Given this list of marker genes Nt5m, Sar1b, Psmg3, Cfap418, Hebp2, Gm12059, Cdiptos, Rrp1b, Timm10, Akain1, Mef2a, Chrna1os, Rptor, Zfp704 (NCBI Gene Id 269407), Nectin3, Vps18, 1810024B03Rik, Ddx1, Kics2, Disp3, Oma1, Rap1a, Brf2, Gm24016, Tm2d1, Ccnc, Taco1, Myc, Rps27l, Ttk, Tmem101, Gm21092, Mrps2, Polq, Vps51, Ptpn21, Usp28, Hs3st5, Ints1, Aloxe3, Rpph1, Dmap1, Jagn1, Rnf214, Exosc3, Ccdc107, Cacng2, Irak2 (interleukin-1 receptor-associated kinase 2), Mir7b, G0s2 (G0/G1 switch gene 2), Got2, Tmem147os, Wdr24 (NCBI Gene Id 268933), Gm20033, Snx18, Tor1aip2, Trim71, D030047H15Rik, Ly6g6e, Tars2, Spop, Hnrnpdl, Ubac2, Scarna2, Scp2, Tmbim4, Fbxl16, Mettl5, 4930558K02Rik, Blmh, Naf1, Kirrel1, Clptm1, Palb2, Zfp646, Pigc, Zfp637, Fbxo7, Bod1l, Med23, Xrn1, Niban2, Gfm2, Cnih4, Trub2, Pstk, Gpcpd1, Trpc4ap, Zfp738, Tatdn3, Tmem115, Ncam1, Dhrs13, Mei4, Zfp280d, Taf15, Rnu12, Abi2, Snord3a, Cul4a, Snord55, Ncbp3, Klhdc4, Eps15, Zfp90, Nipsnap1, Kmt2a, Anln, Scrib, Cntnap2, Epb41l4aos, Lama1, Mfap3l, Gm35986, Vgll3, Hnrnpd, Lamtor2, Gm6728, 4632404H12Rik, Dsg2, Max, Klhl35, Zfyve1, Tcea3, Ctbp1, Trp53bp2, Tmem270, Ndufa5, Rnf216, Tmem134, Calm1, Tmem106a, Gm10644, Fam149b, Gpc2, Magoh, Adrm1, Zfp609, Mrpl17, Scg3, Sp3os, Ap1ar, Rab33b, Hdac2, Ltbp2, Cpsf1, Zfp341, Tgif2, Frg2f1, Dusp28, Gm11292, Mup6, Taf4, Gm11175, Ppif, Plpp1, Ehd1, Prelid2, Ankrd40, Uchl5, Ints15, Plscr1, Syt7, Stx18, Lrrc75a, 5430400D12Rik, Nipsnap2, Cltc, Ephb4, Pcid2, Bcl3, Irf2bpl, Nkiras2, Denr (NCBI Gene Id 68184), Timm23, Sec63, 6430590A07Rik, Dcaf10, Gm5444, Slc33a1, Mien1, Mrps27, Zfp467, Gorasp2, Ndor1, Gm16046, Adam17, Plec, Matcap2, Man2c1os, Homer3, Mfsd4b5, Dab1, Kbtbd7, Cacnb3, Ccdc136, Akirin1, Galk2, Zfp69, Pdpk1, 8430429K09Rik, Rassf2, Pheta1, Psmd3, 1810041H14Rik, Gm13483, Exosc8, Dctn5, Bcat1, Rhot1, Mylpf, Fkbp1a, Cdca5, Rwdd1, Vps37d, Zfp790, Foxn3, Dhcr24, Kcnn2, Kcnb1, Gm11592, Polr1b, Zfpl1, Afg1l, Parm1, Sf3a3, Nanog, Gm16794, Ccdc88a (NCBI Gene Id 77927), Dpagt1, Gm26654, Mnat1, Gm12827, Snhg17, Reps1, Atxn1l, Mllt1, Tacc1, Topbp1, Ddit4, Gt(ROSA)26Sor, Tmem203, Ptcd2, Cops8, Cenps, Stoml2, Gm10433, Glis2, Cdkn2aip, Pafah1b3, Snord13, Tfam, Cnppd1, Ndrg3, Ube2ql1, Fcho2, Ube3c, Ctu2, Prkag1, Mphosph10, Cdk7, Eif3d, Gm26812, C920006O11Rik, Ptrh2, Litaf, Zdhhc17, Nop14, Gatad2b (NCBI Gene Id 404569), Gm26330, Patz1, Pxn, Efcab7, Cd63, Apba1, Rsrc2, Aars2, Zfp64 (NCBI Gene Id 22722), Pcnp, Apcdd1, Trmu, Parg, Eif3g, Pole3, Kbtbd4, Plekha4, Vmp1, Ypel1, Gucd1, Crot, Mrps31, Pik3c3, Sp3, Atad2b, Prrg2, Man2c1, Snora17, Hddc3, Sez6 (seizure related gene 6), Cog8, Nme6, Ssrp1, Pde5a, Gm15173, Dlst, Tmem63b (transmembrane protein 63b), Arhgef12, Pkdcc (protein kinase domain containing, cytoplasmic), Cln6, Ro60, Klhl20, Ybx3, Notum, Trnt1, Polr3c, Zfp131, Tbx3, Tsc22d1, Pknox1, Abcb4, Pcolce, Nsfl1c, Rps17, Jup, Piezo1, B4galt7, Ssbp1, Raf1 (NCBI Gene Id 76876), Hspe1, Mrpl30, Nus1, Tfeb (transcription factor EB), Lasp1, Fem1b, Gne, Jak2, Dgkz, Slc35b2, Gm14963, Dpy19l4, Setdb1, Pex12, Insr, Fam133b, Pabpc4, Xrcc6, Arhgef1, Fntb, Ccdc68, Spin4, Champ1, Tmed5, Pde8a, 4930581F22Rik, Lgals8, Abhd18, Cnpy2, Chek1, Tbc1d7, Isy1, Smg8, Xrcc5, Sos1, Atp6v1d (NCBI Gene Id 73834), Adgrv1, Wdr36, Ass1, Itgbl1, Tmem147, Nme1, 3000002C10Rik, Gm15567, Dctn6, Tnrc18, Cops7b, Slc35f1 (NCBI Gene Id 99729), Ccdc103, Pfas, Itgb3bp, Slc15a4, Pcif1, Pygo2, Scrn2 (NCBI Gene Id 27665), Ints10 (NCBI Gene Id 70885), Eftud2, A930029G22Rik, Api5, Sphk2, Enoph1, Angel1, Atp6v1a, Mtg1 (mitochondrial ribosome-associated GTPase 1), Nynrin, Atxn7l2, Ndufs3, Zfp560, Usp38, Rdm1, Mrpl14, Fbxw8, Pard3, Ddx18, Erc2, Mir762, Fam216a (family with sequence similarity 216, member A), Sik2, Lypla1, Notumos, Necab2, Seh1l, Ints5, Banp, Hook2, Foxo6, Ier3ip1, Zfp523, Hus1, Nploc4, Snord49a, Phlda3, Tuba1c, Rps8, Mir8109, Wbp4, Banf1, Slc4a2, Gnb2, Fibp, Scrt1, Dffb, 1700057H15Rik, Nvl, Rbl2, Svop, Kifc5b, Inpp5f, Cenpe, Retreg2, Gm16537, Ciz1, Polr1has, Eefsec, Gm13523, Ubqln4, Hdhd2 (haloacid dehalogenase-like hydrolase domain containing 2), Vamp4, Ccdc102a, Slc39a13, Gins3, Epg5, Notch2, 1110018N20Rik, Rrn3, Trip4, Oxr1, Gm2093, Rerg, Slc35b1, Gtf2h2, Mrps33, Atp5mc2 (ATP synthase membrane subunit c locus 2), Nfkbil1, Smarcd2, Klhl34, H13, Wdfy1, Ltbr, Crnde, Gm23639, Numbl, Dhx38, Sh3gl1, Bcl7c, Ddx55, Dnttip2, Calb2, Ago1, Atn1 (atrophin 1), Ddx10, Dph1, Trp53i11, Stoml1, Man2a2, Hexim1, Zfp606, Mitd1, Rnf220, Ddx46, Smg6, Mrpl1, Aar2, Ube2j2, Zmynd8 (zinc finger, MYND-type containing 8), Mrpl20, Ap4e1, Taf1b, Enkd1, Vps4a, Fam8a1, Ranbp2, Oxct1as, Tab1, Stx16, Atr, Rbpj, Hepacam2, Gm10517 (predicted gene 10517), Vps72, Rnf185, Traf6, Cdk5rap1, Gpbp1, Eif4a2, Top3b, Zfp568, Tmem222, Ap2b1, Mmadhc, Rpl27, Pex3, Med4, Gaa, Actr3, Atad2, Zcchc4, Acbd4, Cab39, Dennd10, Zscan25, Ift46, Pafah2 (NCBI Gene Id 71926), Plekha5, 5730455P16Rik, Slc48a1, Mcee, Mir688, Foxj3, Gtf2i, Lrp6, Rpl5, Ccdc57, Nfat5, Vps50, Epo, Wdr70, Ccar2, Sec22b, Rnf126, Mtres1, Inhca (NCBI Gene Id 71775), Wdr11, Lrrc59, Ndufs7, Gm14167, Fbxo27, Rabggta, Drg2, Ddost (dolichyl-di-phosphooligosaccharide-protein glycotransferase), Gm15417, Ppard, Pla2g15, Msantd3, Tbp, Ero1b, Pcbp2 (NCBI Gene Id 18521), Scn8a, Atf6, Cdk2ap1rt, Cnih1, Spic, Ndufaf1, H4c16, Fyco1, Aip, Akt1, Ap1s1, Mterf4, Parl, 4921524J17Rik, Rimoc1, Aspscr1, Msh3, Asb15, Mrpl58, Bend5, Vars1, Apbb2, Fbxo22, Exosc4, Zbtb7b, Usp3, Terf2, Gtf3c6, Kntc1, Rad54l2, Itpk1, Mkrn2, Agpat5, Erlin2, Pir, Yae1d1, Trmt10c, Zfp787, Crls1, Grk4, Fscn1, Samd4, Appl2, Mkrn3, Gm15969, Pcsk7, Phf8, Pom121, Acp2, Mast1, Pomk, Gm15408, Eif2b3, Gin1, Cept1, Prss48, Btbd19 (NCBI Gene Id 78611), Bclaf3, Nup54, Agk, Ecd, Zfp11, Tomm22, Cops2, Gtdc1, Yipf6 (Yip1 domain family, member 6), Cyrib, Prmt3, Mbip (NCBI Gene Id 71070), Pxk, Utp3, Oxct1, Dram2, Dhfr, Cep104, Polr2a (NCBI Gene Id 20020), Eif1ad, Gtf2ird1, Heca, Gm9929, Snord49b, Glt1d1, Asf1b, Opa1, Phldb2, Ints12, Nuf2, Acsf3, Vamp1, Skic8, Arid1a, Amz1, Chd9 (chromodomain helicase DNA binding protein 9), D5Ertd605e, 4930477E14Rik, Pts, Dvl3, Pigm, Ttc4, Chd8, Gstcd, Desi1, Fbxo34, Actl6b, Rbm48, Cox14, Ppat, Mrpl44, Rph3a, Mrpl21 (mitochondrial ribosomal protein L21), Nip7, Haspin, Srr (serine racemase), Syt9, Ube2q1, Det1, Spp1 (secreted phosphoprotein 1), Snx17, Arih1, Tbpl1, Gpn3, Hemk1, Gm16208, 2410006H16Rik, 1110002J07Rik, Gpr19, Smim8, Psmf1 (proteasome (prosome, macropain) inhibitor subunit 1), Calr, Dcp1a, Gabpb2, Sptbn4, Txnl4b, Lsg1, Setd5, Nup62cl, Esrrb, Sema6a, Bms1, Sdc4, Kansl3, Esyt1, Tti2, Tjp2, 1700022N22Rik, Mmgt2, Tinf2, Ankrd46, Rnf115, St3gal4, Celf1 (CUGBP, Elav-like family member 1), Naa35, Trabd2b, Nr1h3 (NCBI Gene Id 99182), Nxph3, Ggt7 (gamma-glutamyltransferase 7), Eml3, Yap1, Rtel1, Nsa2, Ndufb7, Polrmt, App, Pax5, Scaf8, Cenpu, 4933405L10Rik, Pkn3, Ap1g1, Sirt4, Eif2a, Pds5a, Gm28535, H2-T24, Bcl9, Commd1, Cdkn2aipnl, Eif2b4 (eukaryotic translation initiation factor 2B, subunit 4 delta), Ajuba, Ppp1ca, Def8, Pfn4, Sgk1, Zfp668, Rps4l, Sbf1, Ogt, Snhg7os (NCBI Gene Id 638139), Fitm2, Fam118a, Nsl1, Pafah1b1-ps1, Crybg1, Rom1, Taok1 (NCBI Gene Id 67240), Barhl1, Cdipt, Casz1, Trp53, Mettl25, Zfand4, Las1l, Ccdc18, St3gal2, Hspd1, Dennd6b, Elovl6, Qser1, Ppm1f, Gmeb1, Ipo9, Kctd18, Sdad1, Rpl18, Kat6a, Trap1, Eeig2, Nup153, Aurkaip1, Atp6v1g2, Fnip2, Stag3, Zfp619 (NCBI Gene Id 70227), Coq4 (NCBI Gene Id 51846, coenzyme Q4), Lamb3, Asah1, Pex1, Trp53rkb, Dnajc7, Gnas, Ino80b (INO80 complex subunit B), Atg101, Ust, Snrnp200, Rps20, Timm13, Vpreb1a, Rbms2, Ubiad1, Cpne4, Arid3a, Rnf166, Lamc1, Ppp1r8, Def6, Mir7075, 1700122E12Rik, Gm13783 (NCBI Gene Id 100415786), Arl14ep, Alg5 (NCBI Gene Id 99915), Tead1, Ighmbp2, Fzd7, Tpm1, Idh1, Eif2s1, Srrm3, Agtpbp1 (ATP/GTP binding protein 1), Cep164, Kdm3b, Ska1, Ap5s1, Cdc73, Parp2, C1ql4, Prmt5, Lbr, 2610005L07Rik, Sec13, Ccdc50, Leng8, Tsku, Tsc1 (NCBI Gene Id 64930), Mtmr14, 4930589L23Rik, 1700065D16Rik, Magi3, Zfp398, Etfbkmt, Alkbh3, Spty2d1, Xkr6, Limk2, Adnp, Tmem242 (transmembrane protein 242), Fgfr1, Dnaaf6, Snx33, Orai1, Ssbp2, Nosip, Mtmr6, Phf13, Rint1, Chordc1, Brwd1, Bid, Ints4, Srp68, Naa30, E130018N17Rik, Dus1l, Slc35f5, Sucla2, Skil, 4930519P11Rik, Cipc, Trappc9, Ap3s2, Bambi-ps1 (BMP and activin membrane-bound inhibitor, pseudogene (Xenopus laevis)), Capn15, 4921531C22Rik, Tob2, Mob4, Epb41l4b, Gins4, Snrpd3, 5730471H19Rik, Spsb4, Them4, Wrap53, Edc4, Sec24a, Ccdc59 (coiled-coil domain containing 59), Rab39, Wwox, Taok3, Tut7, Fra10ac1, Comtd1, Wdr25 (NCBI Gene Id 212198), Pdzd2, Polr1h, Rbm34, Dpysl3, Xpot, Wars1, Smarcd1, Mettl5os, Naa50, Tor1aip1, D430040D24Rik, Enc1, 6820431F20Rik, Paics, Poldip3, Kctd5, Vps36, Mcm3ap, Snapin, Dnajc11, Zyx, Mrpl39, Scn3b, Cog2, 4933430I17Rik, here is a description of the gene set: Genes containing one or more binding sites for (Chaf1a) in their promoter regions (TSS -1000,+100 bp) as identified by GTRD version 20.06 ChIP-seq harmonization. studied in species Mus musculus from publication Yevshin I, Sharipov R, Kolmykov S, Kondrakhin Y, Kolpakov F (PMID 30445619) Mouse Gene Set: CHAF1A_TARGET_GENES